The following is a description of a gene set: Human Gene Set: GOBP_REGULATION_OF_PROTEIN_LIPIDATION Any process that modulates the frequency, rate or extent of protein lipidation. studied in species Homo sapiens, and this is the list of marker genes: HHATL, RAB3GAP1, PIK3C3, SVIP, DBI, RABL3, RAB3GAP2